Given this list of marker genes STAT3, GJB6, PSEN1, PSENEN, GJB2, LCP2, UBE2A, CARMIL2, CTSC (cathepsin C), BTK, SEC61A1, here is a description of the gene set: studied in species Homo sapiens Human Gene Set: HP_RECURRENT_CUTANEOUS_ABSCESS_FORMATION An increased susceptibility to cutaneous abscess formation, as manifested by a medical history of recurrent cutaneous abscesses. Recurrent cutaneous abscess formation